Given this list of marker genes EXOSC7 (exosome component 7), MAPK11, PARN, DCP2, EXOSC4, EXOSC2, MAPK14, EXOSC6 (exosome component 6), EXOSC8, AKT1, EXOSC1, DIS3, YWHAZ, EXOSC3, EXOSC9, EXOSC5, KHSRP, here is a description of the gene set: KSRP (KHSRP) binds and destabilizes mRNA Human Gene Set: REACTOME_KSRP_KHSRP_BINDS_AND_DESTABILIZES_MRNA species: Homo sapiens